The following is a description of a gene set: Human Gene Set: chr5q14 studied in species Homo sapiens, and this is the list of marker genes: HNRNPA1P12, ZFYVE16, SCAMP1-AS1, RN7SKP34, LINC02161, VCAN-AS1, FAM151B-DT, DHFR, LINC01339, RBBP4P6, AP3B1, ENSG00000248112, RNY3P1, RASA1, SERINC5, OTP, PTP4A1P4, ZCCHC9, RASGRF2, ENSG00000288846, KRT18P45, RPS23, RPL29P15, LINC02144, MTX3, HMGB1P21, ZP3P1, ARSB, TBCA, LHFPL2, EDIL3, HOMER1, ARRDC3, TRMT112P2, RNU6-606P, ENSG00000255647 (novel transcript), MIR4280HG, RPS2P25, TENT2, RPL7P24, MBLAC2, SNORD138, RNA5SP187, RPL5P16, RNU4-90P, RAB5CP2, ACTBP2, TMEM161B-DT, LINC02059, LINC01337, COQ10BP2, MIR9-2HG, CMYA5, RNU6-211P, ARRDC3-AS1, MIR3660, ATG10, ANKRD34B, ENSG00000304127, MEF2C, THBS4, MIR4280, NBPF22P, BHMT, RPL7AP32, THBS4-AS1, SEM1P1, LYSETP1, RNU4-11P, RBMX2P5, ATP6AP1L, SSBP2, RN7SL378P, ATG10-AS1, SPZ1, LINC02488, CETN3, CCT7P2, MEF2C-AS1, FTH1P9, ATG10-IT1 (NCBI Gene Id 100874311), MIR3977, CKMT2-AS1, PCBP2P3, MEF2C-AS2, RPL13AP14, GSCAR, TMEM167A, DBIP2, LINC02058, RBX1P2, RPS27AP9, LUCAT1, LYSMD3, LINC01338, RNU6-183P, LDHBP3, SCAMP1, CKMT2, LINC01949, CCNH, ENSG00000251828, RPS3AP20, POLR3G, RNU6-448P, XRCC4, MSH3, RPS3AP22, JMY, ENSG00000310314, ACOT12, ENSG00000206592, WDR41, EDIL3-DT, ENSG00000287938, RPL5P17, RN7SL629P, DMGDH, RNU6-620P, FAM151B, RASGRF2-AS1, PPIAP79, PPIAP11, H3P23, ATP6V1G1P6, ADGRV1, MIR9-2, HAPLN1, ST13P12, RNU6-727P, VCAN, SCARNA18, BHMT2, COX7C, RN7SKP295 (RN7SK pseudogene 295), TMEM161B, RNU6-804P, LINC01455, SNORA70 (small nucleolar RNA, H/ACA box 70)